Given this list of marker genes Ppox, Fech, Uros, Hmbs, Alad, Alas1, Urod, Alas2, Cpox, here is a description of the gene set: Mouse Gene Set: WP_HEME_BIOSYNTHESIS studied in species Mus musculus Heme biosynthesis